The following is a description of a gene set: part of: Transcriptional regulation by RUNX1 In human hematopoietic progenitors, RUNX1 and its partner CBFB are up-regulated at the onset of megakaryocytic differentiation and down-regulated at the onset of erythroid differentiation. The complex of RUNX1 and CBFB cooperates with the transcription factor GATA1 in the transactivation of megakaryocyte-specific genes. In addition, RUNX1 and GATA1 physically interact, and this interaction involves the zinc finger domain of GATA1. Other components of the RUNX1:CBFB activating complex at megakaryocytic promoters are GATA1 heterodimerization partner, ZFPM1 (FOG1), histone acetyltransferases EP300 (p300) and KAT2B (PCAF), the WDR5-containing histone methyltransferase MLL complex and the arginine methyltransferase PRMT1. In the absence of PRMT1, the transcriptional repressor complex can form at megakaryocytic promoters, as RUNX1 that is not arginine methylated can bind to SIN3A/SIN3B co-repressors. Besides SIN3A/SIN3B, the RUNX1:CBFB repressor complex at megakaryocytic promoters also includes histone deacetylase HDAC1 and histone arginine methyltransferase PRMT6.<br>Megakaryocytic promoters regulated by the described RUNX1:CBFB activating and repressing complexes include ITGA2B, GP1BA, THBS1 and MIR27A. ITGA2B is only expressed in maturing megakaryocytes and platelets and is involved in platelet aggregation. GP1BA is expressed at the cell surface membrane of maturing megakaryocytes and platelets and participates in formation of platelet plugs. THBS1 homotrimers contribute to stabilization of the platelet aggregate. MIR27A is a negative regulator of RUNX1 mRNA translation and may be involved in erythroid/megakaryocytic lineage determination.<br>The RUNX1:CBFB complex stimulates transcription of the PF4 gene, encoding a component of platelet alpha granules, the NR4A3 gene, associated with the familial platelet disorder (FPD), the PRKCQ gene, associated with inherited thrombocytopenia, the MYL9 gene, involved in thrombopoiesis, and the NFE2 gene, a regulator of erythroid and megakaryocytic maturation and differentiation. species: Homo sapiens Reactome Pathway: RUNX1 regulates genes involved in megakaryocyte differentiation and platelet function, and this is the list of marker genes: H2AC7, H2BC4, H2BC12L, RBBP5, TNRC6B, H2AC4, H2BC12, WDR5, THBS1, EP300, MYL9, PRKCQ, ITGA2B, ZFPM1, KMT2B, H2BC21, H2AC20, H2BC1, MIR27A, H2AC18, MOV10, HDAC1, H2AC6, H2AC14, GP1BA, KMT2A, H2BC13, H4C1, KMT2C, TNRC6C, H2BC3, TNRC6A, KMT2D, H2BC15, GATA1, CBFB, PF4, RUNX1, H2BC9, AGO1, H3-3A, SIN3A, SETD1A, H2AJ, PRMT1, SETD1B, H3C15, H2BC14, NR4A3, DPY30, H2AB1, AGO3 (NCBI Gene Id 79910), PRMT6, H2AX, H2BC26, H2AZ2, H3C1, ASH2L, H2BC5, H2BC17, NFE2 (NCBI Gene Id 4778), KAT2B, AGO4, SIN3B, H2BC11